Given this list of marker genes GPR32P1, FPR1, FPR3, FPR2, GPR32, here is a description of the gene set: species: Homo sapiens Combining with an N-formyl peptide to initiate a change in cell activity. Human Gene Set: GOMF_N_FORMYL_PEPTIDE_RECEPTOR_ACTIVITY